The following is a description of a gene set: studied in species Homo sapiens Obstructive azoospermia Absence of any measurable level of sperm in his semen, resulting from post-testicular obstruction or retrograde ejaculation. This can be differentiated from obstructive azoospermia on the basis of testicular biopsy. Human Gene Set: HP_OBSTRUCTIVE_AZOOSPERMIA, and this is the list of marker genes: RPL10L, FBXO43, TAF4B, MSH5, TEX14, TEX11, PDHA2, CATIP, CCDC34, KLHL10, FANCM, SPAG17, TERB2, SOHLH1, NANOS1, ADGRG2, MEIOB, RNF212, DNAH10, MOV10L1, SYCP3, ZMYND15, NR5A1, SHOC1, CFTR, CLDN2, DNHD1, STAG3, TEX15, XRCC2, SYCE1, TERB1, CT55, TDRD9, PNLDC1